Given this list of marker genes BTBD3-AS1, SNRPB2, ENSAP1, RPL7AP13, LINC00658, ENSG00000212517, LINC00654, ENSG00000301081, NDUFAF5, RNU1-55P, PA2G4P2, TRMT6, SNAP25, MIR8062, BMP2, PGAM3P, LINC01713, LIN28AP3, PLCB1, ENSG00000285723, ENSG00000232900, RN7SL864P, RN7SL498P, GAPDHP2, PPIAP17, RN7SL547P, PHKBP1, RPS18P1, RNU6-1159P, RN7SKP69, ANKEF1, MACROD2-AS1, ENSG00000286546, LINC01428, RNF11P2, SDAD1P2, LINC01723, PCSK2 (proprotein convertase subtilisin/kexin type 2), RNU6-115P, FERMT1, ENSG00000232448, TMX4, HIGD1AP15, HAO1, AIMP1P1, MTCO1P59, LINC00687, GPCPD1, RNA5SP475, LINC01751, CASC20, RPS10P2, RNU1-131P, ISM1-AS1, SYNCRIPP1, SPTLC3, LAMP5-AS1, LINC01706, FGFR3P3, TMEM230, MACROD2, ESF1, SRSF10P2, RNU105B, RNU6-278P, PAK5, PLCB1-IT1, PCNA, HSPBAP1P1 (NCBI Gene Id 133039962), RPLP0P1, KIF16B, DYNLT3P1, BFSP1, LINC01722, CRLS1, RRBP1, ENSG00000294328, SLX4IP, UBE2D3P1, RPS3P1, ANAPC13P1, BTBD3, LINC02871, EIF4EP1, RNU6-27P, ENSG00000302234, BANF2 (BANF family member 2), SEL1L2, MACROD2-IT1, PARAL1, CDS2, MCM8-AS1, RN7SKP111, JAG1, TARDBPP1 (NCBI Gene Id 650258), TASP1, OTOR, DNAJC9P1, PROKR2, LRRN4, KANK1P1, RPL23AP6, MCM8, FLRT3, LINC01752, ENSG00000285508, PLCB4, FAT1P1, DSTN, RNA5-8SP7, CHGB, CENATACP1, RPS11P1, ISM1, SNAP25-AS1, LAMP5, SHLD1, ENSG00000303645, RNU6-228P, MIR6870, TMX4-AS1, RPS27AP2, MKKS, here is a description of the gene set: species: Homo sapiens Human Gene Set: chr20p12